Given this list of marker genes Oas3, Ly6a, Zbp1, Trafd1, Psmb9, Tnfaip8l2, Rnf213, Ifitm3, Ifi27l2a, Epsti1, Ms4a6c, Phf11a, Isg15, Cyba, Tspo, Ifit3, Isg20, Ms4a6d (NCBI Gene Id 68774), Lyn, Slfn1, Slfn5, Ppp1r16a, Parp14, Selenow, Dynll1, Ifi35, Mndal, Shisa5, Stat1 (signal transducer and activator of transcription 1), Cyrib (CYFIP related Rac1 interactor B, NCBI Gene Id 76270), Ifit1, Sdc3, Oas1a, Ms4a4c, Irf7, Irgm1, Slfn2, Psmb10, Grn, Phf11b, Slfn8, Rtp4, Fcer1g (NCBI Gene Id 98395), Lgals3bp, Dhx58, Trim30b, Ifi213, Spi1, Ube2l6, H2-K1, Ifitm6, Ifi204, Ifih1, Sp110, Ogfr, Ifi207, Oas2, Oasl2, Rigi, Sppl2a, Ly6e, Capza2, Apobec3 (NCBI Gene Id 80287), Uba7, Psmb8, Sp100, Lst1, Samhd1, Bst2, Ifitm2, Znfx1, Ly6i, Phf11d, Chmp4b, Plac8, H2-T23, Lgals9, Ifi203, Ifi47, Fcgr4, Trim30d, Ppp1r14a, Ifi209, Ccnd1, Xaf1, Pnp, Trim30a, here is a description of the gene set: Cytokines mediate cell-cell communication in the immune system and represent important therapeutic targets. A myriad of studies have highlighted their central role in immune function, yet we lack a global view of the cellular responses of each immune cell type to each cytokine. To address this gap, the authors created the Immune Dictionary, a compendium of single-cell transcriptomic profiles of more than 17 immune cell types in response to each of 86 cytokines (>1,400 cytokine-cell type combinations) in mouse lymph nodes in vivo. A cytokine-centric view of the dictionary revealed that most cytokines induce highly cell-type-specific responses. For example, the inflammatory cytokine interleukin-1β induces distinct gene programmes in almost every cell type. A cell-type-centric view of the dictionary identified more than 66 cytokine-driven cellular polarization states across immune cell types, including previously uncharacterized states such as an interleukin-18-induced polyfunctional natural killer cell state. Genes positively differentially expressed in cell type: cDC2 (conventional dendritic cell type 2) upon treatment with cytokine: IFN-ε in mouse lymph nodes in vivo. Mouse Gene Set: CUI_CDC2_IFNE_RESPONSE_UP from publication Cui A, Huang T, Li S, Ma A, Pérez JL, Sander C, Keskin DB, Wu CJ, Fraenkel E, Hacohen N (PMID 38057668) studied in species Mus musculus